Given this list of marker genes Kcnt2, Chrna7, Slc2a12, Pea15a, Taco1, Kcnh7, Clcn1, Plcb3, Trpv4, Slc22a22, Gabrg1, Nlgn1, Dhrs7c, Kcnip3, Tmco1, Adrb1, Heph, Fgf12, Lrrc8e, Erbb4, Pkd2l2, Slc8b1, Stxbp4, Lrrc55, Slc15a4 (solute carrier family 15, member 4), Adra1a, Slc35b4, Clcn4, Gjb4, Slc46a3, Kcnip4, Ptprc, Ndufs3, Slc17a8, Slc25a25, Spg7 (SPG7, paraplegin matrix AAA peptidase subunit), Atp1b1, Lrrc8c, Abcd1, Trpm6, Chrnb2, Sting1, Slc22a19, Ak1, Slc11a1, Slc4a10, Mfsd12 (NCBI Gene Id 73822), Slc25a44, Slc8a1, Cnga4, Slc43a1, Slc25a47, Slc25a32, Slc15a3, Pml, Spns2, Kcnh2, Kcnj10, Slc2a8, Hap1, Slc22a8, Abcb10, Cacng6, Htr2a, Azin2, Sfxn5, Slc12a4, Pex1, Aspscr1, Cacna2d1, Slc6a7, Tgfb1, Pkd1l3, Cpox, Kcnk12, Tmem165, Tspan13, Slc11a2, Tmc4, Slc6a6, Slc5a5, Homer1, Akap6, Bloc1s3, Ccl21d, Pdpk1, Prkci, Slc6a14, Romo1, Abcg2, Slc25a37, Prkcb, Slc35a3, Gsdme, Atp2b1, Rhcg, Slc25a28, Nfe2l2, Pex16, Aqp1, Psen1, Trpm8, Cxcl10, Rgs7, Fcgr4, Slc6a8, Cxcl9, Nnt, Ocln, Slc30a6, Ptpn11, Slc6a19, Gabrp, Slc38a3, Cacna1i, Slc22a2, Micu1, Slc5a6, Stra6l, Slc10a7, Kcnu1, Hpn, Slc5a8, Prnp (NCBI Gene Id 98923), Ccl19-ps3, Trip11, Aqp9, Slc18a1, Grin3b, Chrnb4, Vmp1, Tram1, Abcb4, Kcnj15, Septin2 (NCBI Gene Id 98678), Atp1b3, Slc36a2, Slc13a4 (NCBI Gene Id 243755), Slc4a1, Lcn2, Kcnq2, Fgf2, Pkd1l1 (NCBI Gene Id 171395), Cttnbp2nl, Clcc1, Zfand2b (zinc finger, AN1 type domain 2B), Cox7a1, Ccl21b, Cacnb1, Slc12a9, Slc22a6, Cox4i2, Slc29a2, Gabrr1, Gjc3, Kcnq1 (potassium voltage-gated channel, subfamily Q, member 1), Abca8b, Ift20, Plcb2, Rgs4, Slc45a4, Tgfb2, Ccl3, Slc6a12, Grik5, Slc27a5, Atp5pb, Cln3, Sco1, Cyba, Mfsd8, Nmur2, Alg10b, Gabra2 (gamma-aminobutyric acid type A receptor subunit alpha 2), Atp13a3, Cybb, Bak1, Slc14a2, Pik3cg (phosphatidylinositol-4,5-bisphosphate 3-kinase catalytic subunit gamma), Aqp3 (aquaporin 3), Nipal2, Lrp6, Pkd2l1, Iscu, Phb2, Slc7a14, Slc29a3, Dnlz, Ddit3, Bcr, Per2, mt-Nd2, Trpm7, Mpc1 (NCBI Gene Id 70697), Arg1, Grin2a, Pex6, Cnih3, Slc17a6, Drd2, Abca3, Chrnb1, Ank3, Micu2, Ndufs8, Enpp1, Otop3, Coro1a, Ptpn6, Fxyd5, Kcnj6, Atp1a3, Slc17a3, Ctss, Ndufa4, Braf, Atp2c2, Crebl2, Atp6v1a, Fxyd6, Cdh17, Clcn5, Grk2, Jph2, Orai3, Ndufv2, C1qtnf12, Abca7, Slc6a21, Cltrn, Scn5a, Kcna2, Slc25a2, Fxyd7 (FXYD domain-containing ion transport regulator 7), Slc35d2, Azin1, Tmem241, Ednrb, Gfap, Slc25a31, Abca12, Slc35f6, Atp5mf, Gria2, Hpca, Trpm4, Timm50, Dmac2l, Slc4a11, Camk2d, Stk39, Gstm7, S100a6, Surf1, Trpa1, Slc5a1, Mfsd14b, Cd36, Atp6v1d, Atp2a1, Slc17a9, Mink1, Slc6a2, Piezo1, Slc12a6, Gpc3, Rnf207, Cnksr3, Pkd1, Slc19a2, Gja1, Slc5a4b, Lrp2, Scn3b, Cacna1c, Kcnj8, Slc16a13, Slc17a5, Abcc1, Usp9x, Prkd1, Snca, Tlr9, Slc24a4, Appl2, Slc5a3, Chrna9, Gabrg2, Plch1, Abcb7, Slc30a1 (solute carrier family 30 (zinc transporter), member 1), Slc12a7, Atp5po, Slc39a12, Hspd1, Slc38a1, Kcnf1, Slc44a4, Itgb1, mt-Co2, Slc25a22 (solute carrier family 25 (mitochondrial carrier, glutamate), member 22, NCBI Gene Id 68267), Slc35f1, Scn1b, Slc7a5, Bhlha15, Gper1, Slc12a1, Edn3, Tmem163, Selenon, Tap1, Cxcl11, Trpm3, Gpd1l, Hnf1a, Kcnmb4, Ndufb7, Slc37a2, Kcns2, Sumo1, Mpv17, Fxyd2, Glra4, Atp6v1f, Diaph1 (diaphanous related formin 1), Scarb1, Slc25a51, Chrna5, Slco6c1, Slc13a3, Abca17, Zfas1, Clca2, Clcn3, Slc28a3, Atp6v0e2, Cpt1b, Slc16a9, Cacna2d2, Park7, Vdac3 (NCBI Gene Id 22335), Kcna7, Atp6ap2, Pacc1, Rtn2, Tspo2 (translocator protein 2), Gimap3, Col6a1, Slc22a14, Slc35d3, Kcnj4, Abcc9, Slc3a1, Tram2 (translocating chain-associating membrane protein 2), Ero1a, Hrh1, Stim2, Cacng8, Grin2c, Casr (NCBI Gene Id 12374), Slc45a2, Itgb3, Dnajc19, Kcnip2, Irs2, Slc44a2, Stxbp3, Ffar1, Trdn, Acsl5, Kcnd1, Slc26a8, Nalcn, Grin2d, Abca4, Slc51a, Kcnk3, Insr, Aqp2, Abca5, Slc26a2, Abca13, Opn3, Slc25a12, Mef2a, Fmr1, Chrna2, Atp6v0e, Tpcn1, Pirt, Slc26a9, Hamp2, Grin3a, Acacb, Srp54c, Kcnd2, P2rx7, Ppp3r2 (protein phosphatase 3, regulatory subunit B, alpha isoform (calcineurin B, type II)), Cacnb4, Slc30a4, Erfe, Slc38a2, Kcnq5, Kcnb2, Kcnk16 (potassium channel, subfamily K, member 16), Orai2, Pawr, Cacng4, Abcg8, Slc26a1, Atp6v1g3, Grpel2, Slc25a29, Ano8, Slc25a30, Atp13a5, Sort1, Atp6v0d2, Slc25a5, Slc15a1, Gjb6, Lep, Sfxn3, Mrln, Sec61a2, Best3, Slc10a2, Ubash3b, Slc6a15, Abcd4, Atp6v1e2, Cldn4, Ccl21a, Ywhah, Kcne1, Atp2a2, Itpr1, Tmem144, Mfsd14a, Abcb6, Nherf1, mt-Atp6, Clec4b1, Gip (NCBI Gene Id 14607), Plcb1, Slc9a6, Slc43a2, Cacna1a, Tmem94, Itpr3 (NCBI Gene Id 21779), Kcna6, Ndufv1, Akap5 (A kinase anchor protein 5), Rhbg, Trpv3, Slc4a7, Inpp5k, Glra3, Wnk2, Sfxn1, Grm1, Slc41a2, Slc25a10, Plcg2, Slc35e4, Slc12a5, Nipal4, Slc12a8, Rap1a, Slc7a8, Slc39a10, Shank1, Letm2, Gabra5 (gamma-aminobutyric acid type A receptor subunit alpha 5), Slc38a4, Nipsnap2, Drd1, Dapk1, Esr1, Atp4a, Hrc, Nat3, Cngb3, Panx1, Ccl19-ps4, Arg2, Kcnj3, Lasp1, Grpel1, mt-Nd1 (mitochondrially encoded NADH dehydrogenase 1), Gpr155, Kcng2, Slc39a7, Kcng3, Htr2b, Cemip, Ank2, C2cd6, Gjc1, Calhm1, Gabra3, Pid1, Fgf13, Cblif, Slc9a3, Plcb4, Hpse, Slc7a4, Gp1bb, Hspa2, Atp13a4, Slc26a3, Slc7a1, Calm3, Rgs2, Slc16a1, Slc17a1, Slc22a4 (NCBI Gene Id 56507), Prf1 (perforin 1 (pore forming protein)), Slc25a27, Tram1l1 (NCBI Gene Id 229801), Cybrd1, P2rx6, Kcns1, Tmem175, Trpc3, Actn2, Slc16a12, Lrrc8b, Gria3, Ostn, Slc44a1, Timm23, Slc47a1, Slc9b2, Slc17a4, Xcl1, Atp5f1c, Slc27a1, Scn2b, P2rx1, Slc39a8, Slc30a7, Rasgrf1, Slc35c2, Scn2a, Slco2a1, Slc38a8, Mfsd2b, Oprk1, Slc9a8, Gpr39, Mpeg1, Atp6ap1, Slco1a1, Tmed10, Tmem109, Slc9a9, Slc7a6, Slc30a9, Epm2a, Cacna1h, Htr2c, Slc4a9, Ccl19-ps1, Anxa6, Trarg1, Psen2, Slc35c1, Atp6v1c1, Slc24a5, Cyb561a3, Pex13, Ins1, Mmp9, mt-Nd4l, Gjb1, Myo5a, P2rx5, Pex2, Slc28a2b, Trpc6, Slc38a10, mt-Nd5, Bmp4, Wnk3, Abca8a, Tmem74, Oprm1, Cacna2d3, Slc39a5, Lonp2, Epo, Scara5, Ikbkb, Slc12a3, Aplnr, Slc50a1, Bloc1s6, Slc5a7 (NCBI Gene Id 63993), Stom, Sestd1, Tmem38a, Slc39a4 (NCBI Gene Id 72027), Abcg4 (NCBI Gene Id 76887), Casq2, Tsc2, Atp1b4, Slc22a16, Rangrf, Bpifa5, Akap9, Slc16a4, Slc37a4, Grik2, Ahcyl1 (S-adenosylhomocysteine hydrolase-like 1), Ucp2, C1qtnf2, Aqp12, AU015836, Abcg5, Emb, Fxn, Atp6v1e1, Tomm70a, Grm7, Abcb9, Abcc6, Kcnk4, Atp5f1d, Cbarp, Gabrr3, Cacna1e, Cacna1b, Slc6a1, Grxcr1 (glutaredoxin, cysteine rich 1), Scn7a, Slc22a17, Ptger3, Slc38a9, Slc4a4, Slc25a20, Tmco3, Gsk3a, Mcoln2, Ryr2, Ywhae, mt-Atp8, Sphk2, Myc (NCBI Gene Id 17869), Rasa1, Atpsckmt, Cacna2d4, Gas6, Adipoq, Dpp10, Hcn3, Cacng1 (calcium channel, voltage-dependent, gamma subunit 1), Slc26a11, Tomm7 (translocase of outer mitochondrial membrane 7), Slc36a3, Slc7a7, Gnb5, Tsc1, Slco3a1, Kcnh4, Yes1, Sfxn4, Mfn2, Dpp6, Timm17b, Kcnk6, Tomm40, Pex26, Shisa7, Asic3, Erbb3, Plce1, Trpc1, Bcs1l (BCS1 homolog, ubiquinol-cytochrome c reductase complex chaperone), Tmem37, Rhag, Flna, Ptpn3, Pcyox1, Slc23a1, Gh, Ano7, Dbi, P2rx4, Large1, Ppp3cb, Atp5pd, Glp1r, Akt2, Il4 (interleukin 4), Atp2b3, Stimate, Asph, Sec61b, Slc6a20a, Slc25a33, Kcnn4, Coa8 (cytochrome c oxidase assembly factor 8), Slc22a5, Rhoq, Scn9a, Ndufs4 (NADH:ubiquinone oxidoreductase core subunit S4), Kcnv2, Prrt1, Cacng5, Slco2b1, Slc16a5, Kcnh5, Glra2, Rem1, Atp6v0b (ATPase, H+ transporting, lysosomal V0 subunit B), Slc16a8, Tmem150c, Pex14, Hspa9 (heat shock protein 9), Gal, Ahr (NCBI Gene Id 193333, aryl-hydrocarbon receptor), Slc25a40, Scn1a, Flvcr2, Slc16a6, Mcoln3, Best2, Slc9a5, Slc17a7, Atp2a3, Slc29a4, Otop2, Slc7a2, Fxyd1, Ripk1, Gsto1, Fhl1, Kcnip1, Cacnb2, Slc25a26, Kcnh6, Aifm1, Pex10, Nr3c2, Gsdma3, Slc20a2, Gopc, Cherp, Slc7a15, Slc20a1, Ano1, Slc6a5, Atp5mc2, Cyc1, Slc18b1, Steap1, Scnn1b, Slc2a10, Cnga1, Atp5mg, Abl1, Slc7a10, Cers1, Slc16a10, Tcirg1, Clic6, Atp5me, Trpv6, Cxcr3, Nipa1, Cyb561d2, Calm2 (calmodulin 2), Slc35e2, Slc8a2, Ano4, Nedd4l, Ccl19, Abca1, Slc25a1, Opa1, Chd7, Slc2a9, P2ry12, Tmem266, Gsdma, Chp1 (NCBI Gene Id 80510), Ano6 (NCBI Gene Id 73015), Sec62, Grin2b, Gabrb2, Lrrc52, Kcnj12, Grid2, Ndufs7, Steap2, Asic4, Clca1, Gsdmc2, Ppp3cc, Mip, Aqp6, Slc23a3, Tomm20, Ncs1, Slc33a1, Fyn, Slc22a23, Edn1, Slc16a14, Tmbim6, Mapk8ip2, Oaz2, Adcy10, Abca2, Slc19a1, Mettl21c, Gm13629, Umod, Grin1, Calhm3, Asic2, Kcnn3, Slc15a2, Arf1, Clcn6, Kcnj9 (potassium inwardly-rectifying channel, subfamily J, member 9), Rasgrf2, Ahi1, F2rl3, Acsl6, Ghitm, Slc6a9, Kcnj14, Sv2a, Atp6v1b1, Crhbp, Lrrc8d, Sri, Nalf2, Wnt3a, Slc25a11, Kcnk9, Glrb, Slc4a2, Tomm20l, Rapgef3, Cd4 (NCBI Gene Id 212762), Ank, Kcnk10, Calm1, Gjc2, Ccr5, Slc2a7, Slc22a1, Slc34a2, Plp1, Atp6v0c, Oscp1, Slc25a15, Ednra, Grik1, Catsper4, Abcb11, Catsper3 (cation channel, sperm associated 3), Kcnq4, Slc31a1, Clcnkb (NCBI Gene Id 56365), Slc7a3, Arl6ip5, Timm17a, Slc25a16, Vdac1, Crh, Chrna6, Ano2, Gja3, Kcnb1, Kcnc4, Atg5, Slc18a3, Kcnab3, Ap3d1, Atp2c1, Atp7b, Tnf, Slc24a2, Slc45a1, Slc22a13, Ccl19-ps6, Slc36a1, Cnnm2, Npsr1, Sec61g, Mrs2, Abcb5 (ATP-binding cassette, sub-family B member 5), Mfsd2a, Pim1, Ano10, Nipal3, Kcnmb2, Atp5pf, Cacng2, Ucp3, Tusc3, Clcn7, Nalf1, Mfsd3, Clic3, Slc22a18, Slc25a36, Kcnk18, Tomm40l, Ptpn22, Gsdma2, Svopl, Abcc8, Kcnk5, Slco1a8, Slco4c1, Ttyh1, Atp13a2, Ubqln1, Mfsd9, Sv2b, Itln1, Slc25a18, Chrna1 (cholinergic receptor nicotinic alpha 1 subunit), Igf1, Ccl21e, Cln8, Sesn2, Cacng3, Slc1a6, Cnga3, Gpr35, Zdhhc7 (NCBI Gene Id 102193), Slc6a11, Grik3, Slco1b2, Slc35e1, Slc37a1, Clip3, Oca2, Slc48a1, Aqp4, Spns1, Sgcb, G6pd2, Grp, Atp5mc3, Slc2a1 (solute carrier family 2 (facilitated glucose transporter), member 1), Abcg1, Slc35b2, Catsper2, Klf15, Trpm5, Glra1, Atp6v0a1 (ATPase, H+ transporting, lysosomal V0 subunit A1), Fkbp1a, Clic1, Slc35e3, Racgap1, Hcn4, Cav3, Sln, Scn11a, Slc9b1, Abca6, Nos1, Atp6v1h, Cacna1d (NCBI Gene Id 97919), Slc32a1, Atp5f1e, Abcb8, Trpm2, Asic1, Spns3, Slc5a9 (solute carrier family 5 (sodium/glucose cotransporter), member 9), Stra6, Hspa5, Atp5f1b, Kcnk1, Ndufa2, Slc47a2, Agrn, Pex5, Hvcn1, Slc26a4, Kcnk2, Atp1a4, Slc22a15, Shisa9, Gp1ba, Ctns, Mcur1, Timm44, Best1, Ldc1, Oaz3, Kcns3, Slc14a1, Plcl1, Jsrp1, Nr4a3 (NCBI Gene Id 18124), Trpv2, Smdt1, Cx3cl1, Chrna10, Chrng, Ccl21f, Slc25a24, Kcnmb1, Slc39a1, Slc6a3, Atp8b1, Slc22a21, Slc43a3, Slc29a1, Slc10a3, Appl1, Cacna1s, Slc15a5 (solute carrier family 15, member 5), Slc39a9, Piezo2, Nlgn2, Calhm2, Slc35a5, Bax, Slc27a4, Kel, Sirt6, Stac2, Slc35f2, Aqp11, Slc2a13, Uqcrfs1, C2cd5, Gabrr2, Slc34a3 (NCBI Gene Id 99048), Aqp8, Slc16a11 (NCBI Gene Id 216867), Car2, G6pdx, Kcnc2, Kcnv1, Slc38a7, Smim43, Fcrl5, Slco1a6, Rps6kb1, Slc39a6 (NCBI Gene Id 106957), Kcnn1, Plcl2, Grik4, Cpt2 (carnitine palmitoyltransferase 2), Hspa8, Nlgn3, Ppp3ca, Ntsr1, Mtor, Gsg1l, Ccdc51, Kcnh3, Mmgt2, Ipo8, Gsdmd, Clcn2, Pam16, Smim6, Slc25a14, Adcyap1r1, Chrnb3, Gabrg3, Slc13a5, Rab11a, Slc1a1, Mcu, Pde4d, Slc26a10, Cngb1, Abcb1a, Fbxo11, Ywhaq, Slc25a45, Ms4a1, Osbpl8, Pou4f2, Slc10a5, Lyn, Pou3f3, Mfsd4b1, Cd63, mt-Co1, Oga, Slc2a5, Kcnk13, Rab4b, Cnih2, Xcr1, Slc38a6, mt-Nd4, Slc25a23, Abcg3, Vdac2, Sfxn2, Repin1, Slc35b3, Pex7, Abcc3, Abcc10, Ace2, Kcnma1, Vamp2, Kcna5, F2r, Slc25a41, Slc2a3, Ucp1, Slc4a8, Slc41a3 (solute carrier family 41, member 3), Slc16a7, Kcnh1, Nfkbie, Slc6a4, Mfsd1, Ndufs1, Vdr, Thbs1, Ttyh3, Cox17, Mrpl18, Slc25a21, Dlg1, Slc17a2, Kcna10, Atraid, Kcnj2, Kcna4, Ehd3, Kcne5, Gja8, Rhd, Chrna3, Tmc1, Gabra1, Atox1, Scn4a, Slc25a39, Gc, Arhgef11, Ace, Slc1a5, Slc1a7, Stim1, Bcl2, Slc36a4, Mmgt1, Slc9a7, Ttyh2, Catsper1, Grm6 (NCBI Gene Id 216727), Ffar4, Slc49a3, Clic4, Pln, Slc19a3, Prkce, Slc39a14, Ins2, Orai1, Pkd2, Nol3, Timm21, Kcnab1, Slc7a9, Slc35a2, Thy1, Hcn2 (hyperpolarization-activated, cyclic nucleotide-gated K+ 2), Tert, Steap4, Slc6a13, Kcnt1, Kcng1, Pik3c2a, Slc13a2, Osr1, Abcc5, Slc44a3, Atp12a, Lck, Slc66a1, Slc22a3, Gria1, Trim37, Neto1, Slc34a1, Slc6a16, Il13, Slc39a13, Cacna1f, Gpm6a, Trpv5, Kcng4, Tap2, Bpifa1, Fgf15, Tcaf1, Fxyd3, Slc28a1, Slco1a5, Ndufs2, Cyb561d1 (NCBI Gene Id 99903), Slco1a4, Actb, Hcn1, Slc10a1, Chrm3, Slc51b, Tmem63b, Abcc4, Atp7a, Fkbp1b, Tmem63c, Ngf, Pex5l, Chrna4, Grid1, Mfsd4a, Snap25, Pcsk9, Gjb2, Slc35a1, Slc7a12, Otop1, Fasl (NCBI Gene Id 14103), Kcne3, Tmem38b, Pnpt1, Nipa2, Gjd3, Bsnd, Ank1, Nedd4, Rbp4, Kcnh8, Gabrb1, Ano9, Slc1a3, Tfrc, Svop, Slc1a4, 1810037I17Rik, Abcb1b, C3, Akt1, Exoc4, Flvcr1, Itpr2, Itgav (NCBI Gene Id 76358), Panx2, Gabra4, Slc35b1, Slc5a11, Tpcn2, Calhm6, Kcna1, Slc9a4, Slc25a3, Clca4a, Prkca, Slc5a10, Kcnc3, Il1b, Plch2, Cracr2a, Slc10a6, Ano3, Uqcrh, Slc13a1, Arl6ip1, mt-Co3, Aqp7, Lrrc8a, Slc2a4, Srp54a, Oxsr1, Cnnm4, F2, Slc22a27, Mpc2, Hamp, Slc4a3, Rnasel, Gnb2 (NCBI Gene Id 14693), Gimap5, Strit1 (small transmembrane regulator of ion transport 1), Slc4a5, Scn10a, Fgf14, Atp4b, Atp5mc1, Irs1, Clca3a1, Cacna1g, Rnasek, Acsl1, Slmap, Casq1, Slc25a43, Slc30a3, Scnn1a, Bin1, Apol11a, Slc30a10, Slc2a2, Cftr, Stac, Pth, Slc5a4a, Kcnj13, Slc31a2, Slc3a2, Rgs9, Kcnab2, Sec61a1, Atp6v0a2, Chrm5, Kcnj16, Slc30a2, Reln, Adipor2, mt-Nd6 (NCBI Gene Id 17722), Met, Cldn17, Ccn2, Mlc1, Slc23a2, Tesc, Htr3b, Slc2a6, Gp5, Slc9a1, Afg3l2, Atp2b4, Ccl19-ps5, Upk3b, Prkcd, Slc37a3, Cnga2, Micu3, Fgf21, Kcnj5, Septin7, Aqp5, Kcnk15, Xpr1, Htr3a, Tmem63a, Gfer, Calhm5, Slc7a11, Gja10, Wnk1, Gabrb3, Scn4b, Gabre, Slc22a20, Slc40a1, Slc35g1, mt-Cytb, Wwp2, Slc8a3, Cd19, Slc45a3, Kcna3 (potassium voltage-gated channel, shaker-related subfamily, member 3), Trpc4, Gp9, Plcg1, Akap7, Ralbp1, Tmem30a, Kcnd3, Abca9, Ms4a2, Wnk4 (WNK lysine deficient protein kinase 4), Mfsd10, Grb10, Oaz1, Slc25a19, Abcc2, Gabrq, Slc25a4, Slc46a2, Lhcgr, Atp1a2, Scnn1g, Atp13a1, Mcoln1, Atp1a1, Jph3, Slc30a5, Slc38a11, Gpr89 (G protein-coupled receptor 89), Slc16a3, Kcnc1, Slc18a2, P2rx2, Dmd (dystrophin, muscular dystrophy), Ndufa10, Slc25a13, Tmc2, Ibtk, Capn3, Maip1, Kcnj1, Dtnbp1, Chrne (NCBI Gene Id 11448), Calhm4, Slc26a7, Slco4a1, Atp1b2, Fxyd4, Atp5f1a, Tst, Slc35d1, Ahnak, Slco1c1, Nppa, Prss8, Hif1a, Kcne4, Bdkrb1, Lrrc38, Slc1a2, Slc30a8, Slc39a3, Dnajc15, Cav1, Abcd2, Slc5a12, Capn10, Mcub, Ifng (interferon gamma), Pex12, Kcnq3, Slc6a17, Kcne2, Mapk14, Trpm1, Ppp3r1, Crbn, Lrrc26, Kcnk7, Ano5, Ppif, Slc10a4, Slc22a12, Drd4, Fabp5, Abcc12, Abcd3, Slc7a13 (solute carrier family 7, (cationic amino acid transporter, y+ system) member 13), Lime1, Gria4, Myo5b, Adrb2, Slc22a7, Trib3, Tcn2, Atp2b2, Gabra6, Atp6v0a4, Atp6v1b2, Cacnb3, Pou2f2, Slc25a38, Slc39a2, Shoc2, Agtr1a, Slc12a2, Clcnka, Steap3, Agt, Tescl, Slc5a2, Sv2c, Trpv1, mt-Nd3, Sec63, Sorbs1, Hk2, Slc35a4, Atp6v0d1, Slc24a3, Trpc7, Clic5, Snta1, Slc44a5, Kcnrg, Trpc5, Htt, Exoc7, Nipal1, Commd1, Scn8a, Slc9c1, Ptk2b, Amigo1, Kcnn2, Cd2ap, Slc26a6, Zdhhc13, Chchd4, Slc26a5, Gabrd, Tmem120a, Slc39a11, P2rx3, Atp6v1c2, Ryr3 (ryanodine receptor 3), Slc6a18, Scn3a, Trpc2, Asic5, Kcnj11, Aoc3, P2ry6, Panx3, Ubr3, Nherf2, Tmem168, Ryr1, Slc28a2, Cacng7 (calcium channel, voltage-dependent, gamma subunit 7), Sh2b2, Letm1, Slc25a42, Chrnd, Atp6v1g1, Slc16a2, Slc46a1, Slc41a1, Slc9a2, Galr2, Dysf, Slc6a20b, Stac3, Atp6v1g2, Slc24a1, Slc25a17, Slc38a5, here is a description of the gene set: Mouse Gene Set: GOBP_TRANSMEMBRANE_TRANSPORT studied in species Mus musculus The process in which a solute is transported across a lipid bilayer, from one side of a membrane to the other.